Given this list of marker genes VN1R1, VN1R17P, VN1R5, VN1R2, VN1R4, VN1R3, here is a description of the gene set: Combining with a pheromone to initiate a change in cell activity. A pheromone is a substance used in olfactory communication between organisms of the same species eliciting a change in sexual or social behavior. Human Gene Set: GOMF_PHEROMONE_RECEPTOR_ACTIVITY species: Homo sapiens